The following is a description of a gene set: species: Homo sapiens from publication Sobolev O, Binda E, O'Farrell S, Lorenc A, Pradines J, Huang Y, Duffner J, Schulz R, Cason J, Zambon M, Malim MH, Peakman M, Cope A, Capila I, Kaundinya GV, Hayday AC (PMID 26726811) Genes down-regulated in peripheral blood mononuclear cell -7d vs 0d in adults (18-64) (low AE subjects vs medium/high AE subjects) after exposure to Pandemrix (A/California/7/09 (H1N1)), time point 0D Human Gene Set: SOBOLEV_PBMC_PANDEMRIX_AGE_18_64YO_LOW_VS_MEDIUM_HIGH_ADVERSE_EVENT_SUBJECTS_0DY_DN Adjuvanted vaccines afford invaluable protection against disease, and the molecular and cellular changes they induce offer direct insight into human immunobiology. Here we show that within 24 h of receiving adjuvanted swine flu vaccine, healthy individuals made expansive, complex molecular and cellular responses that included overt lymphoid as well as myeloid contributions. Unexpectedly, this early response was subtly but significantly different in people older than ~35 years. Wide-ranging adverse clinical events can seriously confound vaccine adoption, but whether there are immunological correlates of these is unknown. Here we identify a molecular signature of adverse events that was commonly associated with an existing B cell phenotype. Thus immunophenotypic variation among healthy humans may be manifest in complex pathophysiological responses., and this is the list of marker genes: LYZ, NRG1, HK2, CLEC4D, TMEM121B, SIRPA, CD163, GLT1D1